The following is a description of a gene set: The chemical reactions and pathways involving vitamins. Vitamin is a general term for a number of unrelated organic substances that occur in many foods in small amounts and that are necessary in trace amounts for the normal metabolic functioning of the body. Vitamins may be water-soluble or fat-soluble and usually serve as components of coenzyme systems. Human Gene Set: GOBP_VITAMIN_METABOLIC_PROCESS studied in species Homo sapiens, and this is the list of marker genes: TNF, PNPO, GCLC, PM20D2, RBP1, MMACHC, TPK1, AIFM2, AASDHPPT, VKORC1L1, GSTO2, UGT1A4, SHMT1, CD320, MMAB, NFKB1, RFK, VNN1, GGCX, ACP3, THTPA, TKTL1, NPC1L1, PDXK (pyridoxal kinase), CYP2W1, SLC19A1, FLAD1, MTRR, AMN, NNMT, MMAA, SLC19A2, CYP4F12, CYP3A4, PIAS4, LRP2, SLC52A3, TTPA, MTHFS, SLC2A3, SLC25A16, MMADHC, PSAT1, LGMN, SLC23A1, FGF23, RDH10, CYP27A1, CYP4F2, BCO1, SLC25A19, CYP2R1, CYP24A1, CYP27B1, SLC2A1, PLPBP, FGFR1, CYP4F3, ALPL, ABCD4, CYP4F11, NQO1, CYP26A1, DHFR, SELENON, GSTO1, CYP26B1, SNAI2, DHFR2, SLC25A42, PLTP, BTD, MTR, GFI1, VNN2, VKORC1, SNAI1, RPE65, GC, SLC25A32, CYP26C1, PANK2, IFNG, ALDH1A2, PANK4, LRAT, MTHFD2, CBR3, FPGS, PDXP, CUBN, SLC19A3, RLBP1, SLC52A2, MCCC1, SLC52A1, RBP2, CYP11A1, ALDH1L2, CLSTN3, AKR1C3, UBIAD1, CBR1, LIPA, ERO1A, MTHFD1, MTHFD2L, FOLR1, PRMT3, DHFRP1, SLC5A6, CYP1A1, CLYBL, SLC46A1, UGT1A3, CYP4F8, ATP1A2, HLCS, SLC23A2